Given this list of marker genes KCNN2, ELOVL1, TELO2, PPP1R21, MPDZ, PPP2R5D, LYST, TMEM216, PEX11B, PNPO, SLC16A2, ALX4, HPS6, ERLIN2, SPTBN2, GFER, RARS1, MTR, MKS1, ACBD5, MPC1, ITPR1, TMEM106B, NPHP4, PLP1, GJC2, here is a description of the gene set: Human Gene Set: HP_ROTARY_NYSTAGMUS Rotary nystagmus species: Homo sapiens A form of nystagmus in which the eyeball makes rotary motions around the axis.